The following is a description of a gene set: Any process that results in a change in state or activity of a cell (in terms of movement, secretion, enzyme production, gene expression, etc.) as a result of a cholesterol stimulus. species: Homo sapiens Human Gene Set: GOBP_CELLULAR_RESPONSE_TO_CHOLESTEROL, and this is the list of marker genes: PTCH1 (NCBI Gene Id 8015), GRAMD1A, CES1, MIR185, MLC1, MIR96, GPLD1, GRAMD1B (GRAM domain containing 1B), NFE2L1, INHBA, SMO, CYP7A1, INHBB, LRP8 (LDL receptor related protein 8), OSBPL7, ABCA1, LRP6, GPR155, DAG1, MIR182, GRAMD1C